Given this list of marker genes Irf1, Ripk2, Hlx, Ccl19, Ccr2 (NCBI Gene Id 235692), Ccr7, Socs5 (suppressor of cytokine signaling 5), Anxa1, here is a description of the gene set: studied in species Mus musculus Any process that activates or increases the frequency, rate or extent of T-helper 1 cell differentiation. Mouse Gene Set: GOBP_POSITIVE_REGULATION_OF_T_HELPER_1_CELL_DIFFERENTIATION